Given this list of marker genes ADGRF2P, CHRNA9, DLD, ADRB2, PTPN13 (protein tyrosine phosphatase non-receptor type 13), MYF6, TNPO1, NUDT4, KCNJ1, SBDS, POLR2A, ABTB3, CAMLG, BTNL8, ARHGEF33, PRRC2C, MTF2, NCOA3, E2F8 (E2F transcription factor 8), LONP2 (lon peptidase 2, peroxisomal), here is a description of the gene set: from publication Chen Y, Wang X (PMID 31504780) Genes predicted to be targets of miRBase v22 microRNA hsa-miR-5195-5p in miRDB v6.0 with MirTarget v4 prediction scores > 80 (high confidence targets). species: Homo sapiens Human Gene Set: MIR5195_5P